The following is a description of a gene set: Abnormal circulating dicarboxylic acid concentration Human Gene Set: HP_ABNORMAL_CIRCULATING_DICARBOXYLIC_ACID_CONCENTRATION Any deviation from the normal concentration of a dicarboxylic acid in the blood circulation. studied in species Homo sapiens, and this is the list of marker genes: GSR, ALDOA, AKR1D1, MMAB, RNU4ATAC, DGUOK (NCBI Gene Id 1716), ATP8B1, GYPC, MMUT, TSHB, ROBO1, SLC4A1, L2HGDH, CD320, CPT2, SUCLA2, UBR1 (NCBI Gene Id 64703), IGF1, LMBRD1, TFAM, PRF1, ALDH7A1, OTX2, OTC, CYP7B1, TRMU, FH, BAAT, NR1H4, EIF2AK3, ABCC2, IFT56, PEX19, IRF5, SLC2A2, HMBS, NKX2-1, UBE2A, MTRR, SUCLG1, CPOX, FARSB, DCDC2, FDFT1 (NCBI Gene Id 2222), PIEZO1, SLC30A10, NHLRC2, HK1, GATA1, VPS50, LBR, FOCAD, MTTP, GCDH (glutaryl-CoA dehydrogenase), VPS33B, UGT1A1, SEC63, PFKM, SPTA1, TNPO3, DUOX2, DUOXA2, PEX14, ABCD3, PAX8, RACGAP1, WDR35, CDAN1, IDH2, RHCE, EPB41, PKLR, MPV17, CHD8, SLC10A1, ZNF699, TSHR, SPTBN1, ETFA, MMEL1, LRP5, POLG2, TPO, SLC19A1, KLF1, LIPT1, TG (thyroglobulin), HSD3B7, MYO5B, ABCB4, MMACHC, KMT2D, KIF23, GPX1, SLC5A5, PKHD1, DNAJC19, IYD, PNPLA6, ALDH6A1, ETFB, PEX2, TNFSF15, ATP7B, MED12, GLRX5, SLC25A13, SLC17A5, POMC, KCNN4, SPIB, TCEAL1, SLCO1B1, FOXE1, SEMA7A, PIGA, MMADHC, ODC1, PAFAH1B1, POU2AF1, ANK1, HBB, SLC51A, RHAG, ALDOB, PRKCSH, SUGCT, IL12A, RHD, NT5C3A, VIPAS39 (NCBI Gene Id 63894), ABCB11, EPB42, UROS, RFX6, SPTB, ABCD4, PRDX1, TMEM67, PGK1, ACSF3, SC5D, IL12RB1, KIF12, SLC35A2, UQCRC2, BLVRA, MMAA, FBP1, LYN, SLC2A1, NAA10, HCFC1, IARS1, AMACR, NKX2-5, GBA1, ETFDH, INSR, SLC26A4, ADK, CASK, OSTM1, SLCO1B3, G6PD